The following is a description of a gene set: studied in species Mus musculus The chemical reactions and pathways involving a polyol, any alcohol containing three or more hydroxyl groups attached to saturated carbon atoms. Mouse Gene Set: GOBP_POLYOL_METABOLIC_PROCESS, and this is the list of marker genes: Cyp2r1, Dhfr, Plcd1, Plcg1, Isyna1, Sptssa, Sphk2, Sgpp1, Spr, Gykl1, Tkfc, Plcb1, Abca2, Synj2, Dysf, Grk3, Itpkb, Sord, Ippk, Cyp24a1, Gch1, Pten, Plpp3, Pck1, Myof, Galr2, Adcyap1r1, Degs2, Mogat1, Plpp2, Impa1, Scp2, Pcbd2, Gpd2, Mogat2, Pou1f1, Myh9, Ppip5k2, Pth1r, P2ry1, Sptlc1, Dgat2, Sptlc3, Gk, Mas1, Itpkc, Sptlc2, Ipmk, Itpka, Gper1, Akr1b1, Pla2g4a, Pcbd1, Itpk1, Ip6k3 (inositol hexaphosphate kinase 3), Nudt10 (NCBI Gene Id 102954), Coq2 (NCBI Gene Id 71883), Slc5a3, Plcb3, Impa2, Prkg1, Tpi1, Agk, Cd244a, Fkrp, Cyp27b1, Asah2, Snca, Galk1, Avpr1b, Pck2, Ip6k2, Ip6k1, Ptafr, Gk2, Angptl3, Acer1, Pgp, Mecp2, Ntsr1, Cyp27a1, Pts, Coq3, Plek, Acer3, Ppip5k1, Qdpr, Lrp2, Plcg2, Naaa, Acer2, Lep, Lhcgr, Got1, Nudt4, Miox, P2ry6, Nudt3, Gk5 (NCBI Gene Id 320574), Asah1 (NCBI Gene Id 67617), Sphk1, Ephx1, Pth, Inppl1, Plpp1, Sgpp2, Gba1, Sptssb, Nudt11